Given this list of marker genes MAPKAPK2, ELK1, RAP1A, GNAS, MAP2K1, NR3C1, HTR4, BRAF, MAPK3, SRF, RPS6KA5, MAP2K2, ATF1, ELK4, MAPK1, EGR1, CREB1, HTR6, HTR7, here is a description of the gene set: Human Gene Set: WP_SEROTONIN_RECEPTOR_467_AND_NR3C_SIGNALING studied in species Homo sapiens Serotonin receptor 4/6/7 and NR3C signaling